Given this list of marker genes SS18L1, ACTB, SMARCD3, ACTL6A, ARID1B (NCBI Gene Id 645070), SMARCB1, ACTL6B, DPF2 (NCBI Gene Id 5977), SMARCC1 (SWI/SNF related, matrix associated, actin dependent regulator of chromatin subfamily c member 1), SMARCE1, SMARCA4, SS18, BCL7A, BCL7C, ARID1A, DPF3, PHF10, SMARCA2, BCL11B, SMARCC2, SMARCD1, DPF1, SMARCD2, BCL7B, BCL11A, here is a description of the gene set: Human Gene Set: REACTOME_FORMATION_OF_NEURONAL_PROGENITOR_AND_NEURONAL_BAF_NPBAF_AND_NBAF Formation of neuronal progenitor and neuronal BAF (npBAF and nBAF) species: Homo sapiens